Given this list of marker genes MTND5P11, CARS1, MT-CYB, CD22, AGGF1, LINC00667 (NCBI Gene Id 400642), MTCO3P12 (NCBI Gene Id 107075270), NCOA7, GALNT7, TMEM131L, LINC02598, SLC8A2, CDK17, MC5R, KATNIP, MIR548S, ZNF225-AS1, TMEM132A, UTS2, RFPL2, LINC01596, CNEP1R1, LIPF, THUMPD3, FAM230G, NBPF1, BAIAP2, ZNF225, LINC02961, ANXA2, RCAN1, ZNF546, ACP3, SCTR, LERFS, FAM170A, ZNF608, ICE1, PPP1R12A, MIR4779, ZFP64, ANKRD6, HLA-DQB1, here is a description of the gene set: Genes containing one or more binding sites for (ZNF418) in their promoter regions (TSS -1000,+100 bp) as identified by GTRD version 20.06 ChIP-seq harmonization. from publication Yevshin I, Sharipov R, Kolmykov S, Kondrakhin Y, Kolpakov F (PMID 30445619) studied in species Homo sapiens Human Gene Set: ZNF418_TARGET_GENES